Given this list of marker genes RASSF6, TWF2, AMER1, SLC40A1, EGF, ARHGAP6, RDH12, MAP4K5, RERE, TUSC3, BCOR, FTH1, NR2C2, LAMTOR3, FCRL1, S1PR1, C8orf58, CASP1, UFL1, TMEM176B, CEP70, NUCB2, CETN2, DSE, CD2AP, AIDA, KCNN4, SPNS3 (SPNS lysolipid transporter 3, sphingosine-1-phosphate (putative)), YEATS4, RNASEL (ribonuclease L), ICE1, TBC1D1, RBL1, HLX, ZNF260, NXPE4, SHISA5, SIAE, UBAC2, TMC6, HNRNPH3, SPOP, CTCF, GRK6, NTAN1, HIVEP1, NBDY, NICN1, DIP2A, TRAK1, DHRS7, CYFIP1, SSH1, BAHD1, ALDH6A1, SLC44A3, SLC41A3 (solute carrier family 41 member 3), SERPINI1, KCTD14, STX2, TLR3, MTA3, ANXA4, C1orf52, FAM117B, GYG1, EPB41L2, DYNC1I2, FBXW10 (NCBI Gene Id 10517), RFX5 (NCBI Gene Id 5993), ARMCX2, MINK1, SNX29, KMO (NCBI Gene Id 8564), SH3GLB1, TM7SF3, CAMKMT, SEC24D, GNGT2, SDF2, ING1, NUAK2, FMO5, ENTPD5, CCPG1, ACAA2, LYNX1, SVIL (NCBI Gene Id 6840), SETD1B, C1orf54, MOSPD3, PICALM, PBXIP1, VAMP8, IRGM, LYSMD3, FBXL17, CRAMP1, LBR, PAIP2, EHHADH, FANCM, CHUK, PADI2, TNK2, C12orf57, C9orf85, RREB1, CBY1, CKAP4, UBP1, CPT1A, RAB33B, IFIT2, SLCO5A1, MKS1, RAB35, ERMARD, SIDT1 (SID1 transmembrane family member 1), PCCA (propionyl-CoA carboxylase subunit alpha), CPSF3, LIAT1, EDEM3, LPIN2, TMEM181, SGPP1, MXI1, DEF6, SMIM14, NAPG, S100A11 (NCBI Gene Id 6282), MEF2C, LINC01160, MTMR6, MARVELD2, CREBL2, ARHGEF6, DNMT1, INTS4, MAPK9, ANXA2 (NCBI Gene Id 792), SLC2A1, CD99L2, HLCS, IRF2, APOBEC1, TMEM234, ZYG11B, TMEM26, PCMTD2, PIERCE2, TAX1BP1, HLA-DRA, IER5, PCOLCE, SPATA7, NAE1, CTSC, DENND2D, TNNT3, AZI2, SYPL1, LRRC23, NCOA3, RGS19, SNAP29, DAZAP2, DFFA, TNFRSF13B, CDC42EP4, CASP7, RNF139 (ring finger protein 139), CEP350, LIFR, GAB3, GALNT6, RINL, MARCHF7 (NCBI Gene Id 64844), MICU2, CD40, VWA7 (NCBI Gene Id 80737), CYBB, GCC1, INCA1, KHK, ALDH3A2, TRIM35, NCAPG, MYH9, CCDC93, STXBP2, ZMIZ1, BTBD1, RUFY1, PRUNE1, SOCS3, RETREG1, TGFB3, GIMAP1, KANSL1, here is a description of the gene set: species: Homo sapiens Human Gene Set: GSE411_100MIN_VS_400MIN_IL6_STIM_MACROPHAGE_UP Genes up-regulated in macrophages treated by IL6: 100min versus 400min. Effects of SOCS3 on the transcriptional response of bone marrow-derived macrophages to IL-6. Fetal liver cells from SOCS3+/+ or SOCS3-/- embryos were used to reconstitute recipient mice. Donor derived bone marrow from these mice was differentiated to macrophages. Macrophages were either unstimulated, or stimulated for 100 or 400 minutes with 10 ng/ml IL-6. from publication Lang R, Pauleau AL, Parganas E, Takahashi Y, Mages J, Ihle JN, Rutschman R, Murray PJ (PMID 12754506)